The following is a description of a gene set: Mouse Gene Set: MIR_6992_5P studied in species Mus musculus Genes predicted to be targets of miRBase v22 microRNA mmu_miR_6992_5p in miRDB v6.0 with MirTarget v4 prediction scores > 80 (high confidence targets). from publication Chen Y, Wang X (PMID 31504780), and this is the list of marker genes: Uri1, Wipf2, Mal2, Dmbt1, Ube2g2, Asb11, Zfp704, Syt1, Zfp120, Pdcd5, Tgm4, Tmcc1, Prkd2, Ppp1r12c, Zfp972, Zfp655, Ncf1, Aldh2, Ccdc71, Chga, Nell2, Zfp781b, Dlgap4, Hnrnpf, Grap2, Trpm7, Scel, Peg10, Trpd52l3, Insm1, Mmd, Zbtb5, Pla2g4c (phospholipase A2, group IVC (cytosolic, calcium-independent), NCBI Gene Id 52126), Brd1, Dpf3, Onecut3, Map2k1, Bzw1, Chst2, Slc26a5, Ttc9, Gm20604, Txnrd1, Slc41a1, Myom3, Prrc2b, Atp10a, Ube2k (NCBI Gene Id 53323), Rock1, Ptcra, Krtap9-20, Crocc2, Larp1, Sox7, Pptc7, Pdcd1lg2, Abat, Cdh16, Nos1, Arhgap32, Tent4a, Scpppq1, Ranbp10, Gas8, Akap6, Tnfrsf13c, Abcg4, Osm, Sorbs3, Wiz (widely-interspaced zinc finger motifs), Qpct, L1cam, Nsun5, Fgf13, Sema4c, Rag1, Slc4a8, Cd160, Hes2, Epha5, Dstn, Fgr, Zfp955a, Mob1a, Pkia, Dlst, Bmpr1a, Mier1, Lrrc51, Nrf1